The following is a description of a gene set: Mouse Gene Set: GOBP_C21_STEROID_HORMONE_METABOLIC_PROCESS studied in species Mus musculus The chemical reactions and pathways involving C21-steroid hormones, steroid compounds containing 21 carbons which function as hormones., and this is the list of marker genes: Hsd3b9, Bmp2, Akr1c6, Dgkq, Scnn1b, Srd5a1, Akr1c14, Stard3 (NCBI Gene Id 59045), Akr1cl, Hsd3b8, Bmp6, Dhrs9, Akr1c19, Akr1c21, Rest, Bmp5, Cyp21a1, Egr1, Clcn2, Stat5b, Akr1c12, Akr1d1, Akr1c13, Akr1c20, Cyp19a1, Cyp11b2, Akr1c18, Hsd3b4, Hsd3b6, Ednrb, Hsd3b2, Hsd3b5, Cyp17a1, Kcnma1, Cyp46a1, Cacna1h, Hsd3b3, Cyp11b1, Wnt4, Ppargc1a, Dkk3, Scp2, Dab2, Cyp11a1, Cyp2d22, Hsd3b1, Hsd17b10, Cyp27a1, Afp